Given this list of marker genes Ifnab, Gm13271, Ifna7, Ifna4, Ifna11, Ifnk, Ifna5, Gm13283, Ifna16, Ifna14, Ifna9, Ifne, Gm13275, Ifna1 (NCBI Gene Id 15962), Ifnb1, Gm13272 (NCBI Gene Id 545648), Gm13276 (predicted gene 13276), Ifna13, Ifna2, Ifna12, Gm13277, Ifnz, Ifna6, Ifna15, here is a description of the gene set: studied in species Mus musculus Binding to an interferon-type I receptor, a heterodimeric complex composed of an alpha subunit (IFNAR1) and a beta subunit (IFNAR2). Mouse Gene Set: GOMF_TYPE_I_INTERFERON_RECEPTOR_BINDING